The following is a description of a gene set: DNA Replication studied in species Homo sapiens Human Gene Set: REACTOME_DNA_REPLICATION, and this is the list of marker genes: PCNA, CCNE1, PSMD12, ADRM1, H2AC19, H4C14, H4C16, POLD4, H3C14, RPA4, MCM8, GINS4, PSMC5, H4C9, PSMD6, CCNA1 (cyclin A1), PSMD8, ANAPC15, RNASEH1 (NCBI Gene Id 246243), PSMD14, H2AC6, H2AC4, H2BC6, H3C11 (NCBI Gene Id 8354), H2AX, PSMB6, H3C15, H3C6, POLG2, TWNK, H2BC3, ANAPC10, ORC3 (origin recognition complex subunit 3), ANAPC16, H2BC12, H3C13, PSMC1, CDT1 (chromatin licensing and DNA replication factor 1), PSMA3, H2BC26, LIG1, POLE, CDC16, H2BC8, H2BC9, GINS2, RPA1, RFC2, H2AC18, ORC1, RPA3 (replication protein A3), UBC, MCM5, CDC45 (cell division cycle 45), ORC6, H2BC5, H2BC7, RFC3, H4C13, DNA2, POLD1, H2AJ, RFC1, SKP1, H4C11, H3C3, FEN1, POLD2 (DNA polymerase delta 2, accessory subunit), H3C12, H4C4, H3C8, UBE2C, MCM2, H3-3A, H4C5, H3C7, MCM7, ANAPC5, PSMC3, CDC27, CUL1, PSMB1, H3C1, ANAPC4, PSMD3, H4C6, ORC5, EXOG, H2BC10, H4C1, H2AZ2, PSMC4, PSMD2, RBX1 (ring-box 1), PSMD11, H4C15, MCM6, PSMA6, KPNA6, TOP3A, PSMA4, PSMD1, PSMC2, PSMC6, UBB, H4C2, CDK2, PRIM1, H4C12, H4C8, MGME1, PSMA7, PSMB7, ORC2, POLE3, H3C4 (NCBI Gene Id 8351), POLG, PSMB4, GINS3, H2AC8, CDC23, H3-3B, KPNB1, H3C10, H2AC20, KPNA1, UBE2D1, UBA52, ANAPC2, CCNA2, POLE2 (NCBI Gene Id 5427), LIG3, H2BC21, H2BC14, H2AC14, ANAPC1, H2AC7, FZR1, H4C3, UBE2S, H2BC4, POLD3, PSMA5, MCM10, CDC7 (cell division cycle 7), POLRMT, SEM1, CDC6, RFC4, PSMB3, PSMA2, PSMD13, PSMD7, H2BC1, UBE2E1 (NCBI Gene Id 94682), CDC26, GMNN, SSBP1, H2BC15, MCM3, CCNE2, POLE4, RPA2, H2BC12L, H2AB1, H2BC13, H2BC17, POLA1, POLA2, PRIM2, PSMB5, H3C2, GINS1, PSMB2, ANAPC11, ORC4, PSMA1, RPS27A, SKP2, DBF4, H2BC11, RFC5, ANAPC7, MCM4